The following is a description of a gene set: Any process that activates or increases the frequency, rate or extent of mitotic sister chromatid separation. Human Gene Set: GOBP_POSITIVE_REGULATION_OF_MITOTIC_SISTER_CHROMATID_SEPARATION studied in species Homo sapiens, and this is the list of marker genes: CUL3, SKA3, CDC23, BIRC5, MAD2L1BP, ESPL1, CDC20, ANAPC11, CDCA8, ANAPC7, UBE2C (ubiquitin conjugating enzyme E2 C), SKA1, RB1, CDC16, MAD1L1, INCENP, PRAP1, NSMCE2, DLGAP5, AURKB, ANAPC5